Given this list of marker genes LCAT, LMNA, ABCG8, SLC25A13, FHL1, LDLRAP1 (low density lipoprotein receptor adaptor protein 1), APOB, SLC7A7, EPHX2, CEP19, GHR, TMEM199, ABCG5, DYRK1B, SYNE2, LDLR (NCBI Gene Id 3949), LIPA, CCDC115, PCSK9 (NCBI Gene Id 50983), LRP6, LPL, APOA2, EMD, SYNE1, CYP7A1, ABCA2, TMEM43, PPP1R17, SMPD1, TTPA, APOE, ALB, CELA2A, here is a description of the gene set: An elevated concentration of low-density lipoprotein cholesterol in the blood. Human Gene Set: HP_INCREASED_LDL_CHOLESTEROL_CONCENTRATION species: Homo sapiens Increased LDL cholesterol concentration